Given this list of marker genes Gm14115, Gm14116, Nkx2-4, Gm14110, Pax1dt, Gm14107, Pax1, A530006G24Rik, Xrn2, Gm14113, Nkx2-2, Nkx2-2os, here is a description of the gene set: species: Mus musculus Mouse Gene Set: chr2G2